Given this list of marker genes Elovl4, Elovl2, Elovl5, Elovl1, Elovl3, Elovl6, Elovl7, here is a description of the gene set: Catalysis of the reaction: a very-long-chain acyl-CoA + H+ + malonyl-CoA = a very-long-chain 3-oxoacyl-CoA + CO2 + CoA. This reaction is the first (condensation) step of the four-step fatty acid elongation cycle in the endoplasmic reticulum that extends fatty acids of C-16 or longer with an additional 2-C unit. Mouse Gene Set: GOMF_FATTY_ACID_ELONGASE_ACTIVITY studied in species Mus musculus